Given this list of marker genes AKAP9, KCNE2, CACNG4, KCNE3, KCNE4, KCNE5, CACNG8, CACNB1, CACNG6, KCNE1, CACNA1C, CACNB2, KCNQ1, CACNG7, CACNA2D2, here is a description of the gene set: Human Gene Set: REACTOME_PHASE_2_PLATEAU_PHASE studied in species Homo sapiens Phase 2 - plateau phase